Given this list of marker genes AGXT, IDH2, IDH1, GRHPR, MGAT4A, HOGA1, AGXT2, HYI, here is a description of the gene set: studied in species Homo sapiens Human Gene Set: GOBP_GLYOXYLATE_METABOLIC_PROCESS The chemical reactions and pathways involving glyoxylate, the anion of glyoxylic acid, HOC-COOH.